Given this list of marker genes EPHB4, TRPM3, DST, MAPK7, TNFRSF10A, IDH1, EIF2AK4, FGFR4, LEMD3, here is a description of the gene set: Human Gene Set: NOUSHMEHR_GBM_SOMATIC_MUTATED from publication Noushmehr H, Weisenberger DJ, Diefes K, Phillips HS, Pujara K, Berman BP, Pan F, Pelloski CE, Sulman EP, Bhat KP, Verhaak RG, Hoadley KA, Hayes DN, Perou CM, Schmidt HK, Ding L, Wilson RK, Van Den Berg D, Shen H, Bengtsson H, Neuvial P, Cope LM, Buckley J, Herman JG, Baylin SB, Laird PW, Aldape K, Cancer Genome Atlas Research Network (PMID 20399149) Genes showing significantly elevated somatic mutation frequencies in proneural G-CIMP (a CpG island methylator phenotype) GBM (glyoblastoma multiforme) tumors. studied in species Homo sapiens We have profiled promoter DNA methylation alterations in 272 glioblastoma tumors in the context of The Cancer Genome Atlas (TCGA). We found that a distinct subset of samples displays concerted hypermethylation at a large number of loci, indicating the existence of a glioma-CpG island methylator phenotype (G-CIMP). We validated G-CIMP in a set of non-TCGA glioblastomas and low-grade gliomas. G-CIMP tumors belong to the proneural subgroup, are more prevalent among lower-grade gliomas, display distinct copy-number alterations, and are tightly associated with IDH1 somatic mutations. Patients with G-CIMP tumors are younger at the time of diagnosis and experience significantly improved outcome. These findings identify G-CIMP as a distinct subset of human gliomas on molecular and clinical grounds.